The following is a description of a gene set: Human Gene Set: GSE3982_MAC_VS_NEUTROPHIL_DN species: Homo sapiens from publication Jeffrey KL, Brummer T, Rolph MS, Liu SM, Callejas NA, Grumont RJ, Gillieron C, Mackay F, Grey S, Camps M, Rommel C, Gerondakis SD, Mackay CR (PMID 16474395) Genes down-regulated in comparison of macrophages versus neutrophils. In the present study we used Affymetrix oligonucleotide microarrays to produce gene transcription profiles for the major leukocyte types in humans. This comprehensive dataset enabled us to not only establish which genes were expressed in each leukocyte type, but also which genes were expressed in each subset after activation. The used of a comprehensive dataset of gene profiles from all the major human leukocyte subsets enabled a novel and powerful means for identification of genes associated with single leukocyte subsets, or different immune paradigms., and this is the list of marker genes: GSK3B, PCK1, CSNK1G1, BLTP3B (bridge-like lipid transfer protein family member 3B), KANSL1L, OR11A1, SV2A, KPNB1 (NCBI Gene Id 3837), GNB2, ARPC4, KRT23, AATF, SH2B2, EFEMP2, BAZ1A, IFNA5, FBRS, PDLIM2, MADCAM1, FTH1, MED16, SLC25A14, P2RY10, IFNAR2, ADGRG3, ADAMTSL4, DENND5A, ACTR3, GARRE1, ITIH4, FOXP3, EYA1, CHTOP, PSAP, UNC5B, GJD2, ORM1, IL17A, APOF, CDKN2D, SH2D1A, CSGALNACT1, CKB, GPR88, GALNT10, CCNJL, OLAH, PLBD1, PTAFR, MARK3, TREM1, GRIA2, PPP6R1, STX16, COMP, CD53, PUM2, HBE1, EWSR1, SH2D3C, MORN1, TNFAIP3, PSG9, RAB5IF, CABIN1, CX3CR1, PAK2, SOX10, E2F3, ZNF394, BTN3A1, NDST3, BACH1, SCN10A, CCR10, COTL1, GPBP1L1, NMI, TCL1A, DACH1, ZNF473, SCARF1, S1PR4, TAP2, GFI1, SNTG2, MTMR12, HEXIM1, SEC14L1, MAPK8IP3, NRF1, KIR2DL4, DEF6, ARID4A, ARHGEF1, REPS1, CEACAM6, PTPRG, ABCC5, HAUS4, LYN, PPM1E, STC1, SPAM1, TESC, CALCOCO1, SULF1, ARHGEF18, ZNF692, MARF1, CERNA1 (competing endogenous lncRNA 1 for miR-4707-5p and miR-4767), SERTAD3, ADH6, PELI1, SIRPG, IL1RAP, NXF2, ACTB (NCBI Gene Id 60), AZGP1 (NCBI Gene Id 90053), CHAD, MYO16, BIRC2, KRT19P2, LPCAT1, UCP1, YIPF1, CEACAM4, ANKRD12, SPATA1, CRHR1, DICER1, CTDSP1, NLRP3, TMEM47, ARHGAP25, ACAN, ISG20, GDF3, LRRFIP1, PPT1, EXD3 (NCBI Gene Id 54932), MYO9B, UBE2D1, CDK12, SAMD9, JUNB, PISD, ZNF44, ARAF, AQP9, GNMT, LSAMP (NCBI Gene Id 4045), CERS2, ERO1B, OXT, GNAQ, SERP1, APAF1, PAK1, KAT7, EEF1D, S100P, ETV7, SCN2B, ACE2, MSL2, CHRM2, PLXNC1, AGTPBP1, IFNA7 (interferon alpha 7), ZMYND8, TFAP2C (NCBI Gene Id 7022), CTDSP2, SYNE2, PCGF2, C1RL (NCBI Gene Id 51279), CERS4, PARP8, BBIP1, TRANK1, TREH, SLC6A11, RASSF7, TRIM8, SNTA1, ULBP1, MON1B, PAX1, ATRX, FOXO3, PIM2, YIF1B, BTN2A1, ATP1B2, DUSP2